Given this list of marker genes ABAT, RAB3A, SLC1A2, SLC1A3, UNC13B, STXBP1, VAMP2, SYN2 (NCBI Gene Id 6854), SLC6A1, SNAP25, RIMS1, SLC6A11, ALDH5A1, SYN1, CPLX1, TSPOAP1, CHAT, GLS2, LIN7A, PPFIA1, SLC22A2 (solute carrier family 22 member 2), GAD2, DNAJC5 (DnaJ heat shock protein family (Hsp40) member C5), LIN7C, SLC6A12, CASK, LIN7B, SLC17A7, MAOA, GAD1, PPFIA3, HSPA8, SLC22A1, SLC18A2, SLC5A7, SLC38A2, PPFIA2, PPFIA4, SLC1A6, SYT1, SLC1A7, GLS, STX1A, APBA1, SLC32A1, ARL6IP5, NAAA, SLC6A13, SYN3, SLC1A1, SLC18A3, here is a description of the gene set: Neurotransmitter release cycle Human Gene Set: REACTOME_NEUROTRANSMITTER_RELEASE_CYCLE species: Homo sapiens